The following is a description of a gene set: Mouse Gene Set: GOBP_SYNAPTIC_VESICLE_TRANSPORT studied in species Mus musculus The directed movement of synaptic vesicles., and this is the list of marker genes: Btbd8, Cdk5, Dnm1, Ap3b1, Spg11, Ctnnb1, Fgfr2, Ap3b2, Tmem230, Madd, Bloc1s2, Map2, Kif1a, Mx2, Bloc1s1, Snapin, Bloc1s5, Syt4, Kif5b, Lin7b, Bloc1s6, Ap3s1, Arf1, Slc2a4, Kif5a, Synj1, Bloc1s3, Cnih2, Dnm2, Snca, Kif5c, Lrrk2, Dtnbp1, Ap1s2, Rab3a, Tor1a, Kif1b, Pdzd11, Kifc2, Mylk2, Ap3m1, Lin7c, Rab3gap1, Borcs5, Ap3s2, Ap3m2, Bloc1s4, Dpysl2, Ap3d1, Lin7a (NCBI Gene Id 93744), Trim46, Dnm3, Nlgn1, Picalm